The following is a description of a gene set: Signaling by FLT3 ITD and TKD mutants Human Gene Set: REACTOME_SIGNALING_BY_FLT3_ITD_AND_TKD_MUTANTS species: Homo sapiens, and this is the list of marker genes: GRB2, CDKN1A, KRAS, PTPN11, STAT5A, FLT3, BCL2L1, NOX4, NRAS, PIK3R1, PIM1, SOS1, STAT5B, HRAS, GAB2, PIK3CA (NCBI Gene Id 5290)